The following is a description of a gene set: species: Homo sapiens The directed movement of organelles or molecules along microtubules from the cell periphery toward the cell body in nerve cell axons. Human Gene Set: GOBP_RETROGRADE_AXONAL_TRANSPORT, and this is the list of marker genes: PAFAH1B1, FBXW11, DLG2, DYNC1H1, SOD1, RUFY3, KIF1A, NDEL1, AGTPBP1, MGARP, RUFY4, ACTR10, KIF5B (NCBI Gene Id 3830), KIF5A, AGBL4, KIF1B, SNAPIN, NEFL, TMEM108, DST, MAP1A, KIF1C, HAP1